The following is a description of a gene set: This event has been computationally inferred from an event that has been demonstrated in another species.<p>The inference is based on the homology mapping from PANTHER. Briefly, reactions for which all involved PhysicalEntities (in input, output and catalyst) have a mapped orthologue/paralogue (for complexes at least 75% of components must have a mapping) are inferred to the other species. electronically inferred by orthology from the curated human pathway studied in species Mus musculus Reactome Pathway: Interleukin-4 and Interleukin-13 signaling part of: Signaling by Interleukins, and this is the list of marker genes: Il2rg, Jak3, Il13ra2, Socs1, Hsp90b1, Il4, Il13ra1, Tyk2, Il4ra